The following is a description of a gene set: Visual cycle species: Homo sapiens Human Gene Set: WP_VISUAL_CYCLE, and this is the list of marker genes: RDH10, OPN1LW, ABCA4, RDH11, RBP1, RDH8, RDH12, LRAT, RBP3, RPE65, RLBP1, OPN1SW, RHO, RDH5, OPN1MW